The following is a description of a gene set: The chemical reactions and pathways resulting in the formation of any conjugated, water-soluble protein in which the covalently attached nonprotein group consists of a lipid or lipids. Mouse Gene Set: GOBP_LIPOPROTEIN_BIOSYNTHETIC_PROCESS species: Mus musculus, and this is the list of marker genes: Ppm1b, Rabl3, Zdhhc17, Atg5, Golga7, Rb1cc1, Clip3 (NCBI Gene Id 76686), Wipi2, Pik3c3, Zdhhc18, Ppm1a (protein phosphatase 1A, magnesium dependent, alpha isoform), Col6a1, Selenok, Atg13, Zdhhc22, Zdhhc19, Lcat, Zdhhc21, Dbi, Alox12b, Zdhhc7, Zdhhc11, Zdhhc1, Irgm2, Rab3gap2, Zdhhc23, Zdhhc8, Apob, Mttp, Zdhhc14, Abca1, Ulk1, Nmt2, Gba1, Zdhhc5, Map6d1, Rab3gap1, Glul, Atg101, Mboat4, Igtp, Ugcg, Hhatl, Apoe, Hhat, Svip, Zdhhc16, Irgm1, Atg10, Nmt1 (NCBI Gene Id 18107), Zdhhc2, Zdhhc9, Atg16l1, Zdhhc12, Zdhhc3, Zdhhc15, Porcn, Zdhhc6, Apobec1, Atg7, Zdhhc20 (zinc finger, DHHC domain containing 20), Apoa1